The following is a description of a gene set: Any process that stops, prevents or reduces the frequency, rate or extent of mRNA catabolic process. species: Mus musculus Mouse Gene Set: GOBP_NEGATIVE_REGULATION_OF_MRNA_CATABOLIC_PROCESS, and this is the list of marker genes: Slc11a1, Mettl14, Axin2, Dnd1, Nicol1, Thrap3, Tent5b, A1cf, Csde1, Gdnf, Ybx2, Nrde2, Pkp1, Igf2bp3, Hnrnpd, Larp1, Il17a, Eif4enif1, Ikbke, Fxr1 (NCBI Gene Id 99741), Elavl4, Igf2bp2, Rbm46, Taf15, Apobec1, Igf2bp1, Pabpc1 (NCBI Gene Id 18458), Nbas, Tent5a, Secisbp2, Zc3h14, Vip, Dhx9, Traf5, Paip1, Traf2, Ptbp1, Ybx1, Hnrnpc, Tent4b, Dhx34, Pkp3, Zar1, Boll, Arid5a, Larp4b, Tent5c, Hnrnpab, Cirbp, Rbm47, Hnrnpa0, Srsf1, Qki, Syncrip, Fam76b, Myd88, Hnrnpu (heterogeneous nuclear ribonucleoprotein U), Hnf4aos, Tardbp, Mettl16, Dazl, Traf3ip2, Zfp36 (NCBI Gene Id 22695), Tent4a, E2f1, Mtor, Noct, Fus, Vegfa, Elavl1, Tent5d, Dicer1, Tirap, Tob1, Rbm24, Mir466l, Angel2, Mapkapk2, Upf3a, Tnf, Rbm10, Meioc, Rbm38